Given this list of marker genes Folr1, Ece1, Ednra (NCBI Gene Id 14737), Fgf8, Ripply3, Hoxa2, Isl1, Nkx2-5, Nkx3-1, Foxi3, Nog, Bmpr1a, Tgfbr1, Bmpr2, Acvr1, Edn1 (endothelin 1), Adgrf4, Adgrf5, Smarca4, Megf8, Bmp4, Plxna2, Ptch1, Nkx2-6, Six1, Gata3, Eya1, Bmp7, Six4, Tbx2, Tbx1, Bmp5, Hes1, Tgfb2, here is a description of the gene set: studied in species Mus musculus The process whose specific outcome is the progression of the pharyngeal system over time, from its formation to the mature structure. The pharyngeal system is a transient embryonic complex that is specific to vertebrates. It comprises the pharyngeal arches, bulges of tissues of mesoderm and neural crest derivation through which pass nerves and pharyngeal arch arteries. The arches are separated internally by pharyngeal pouches, evaginations of foregut endoderm, and externally by pharyngeal clefts, invaginations of surface ectoderm. The development of the system ends when the structure it contributes to are forming: the thymus, thyroid, parathyroids, maxilla, mandible, aortic arch, cardiac outflow tract, external and middle ear. Mouse Gene Set: GOBP_PHARYNGEAL_SYSTEM_DEVELOPMENT